Given this list of marker genes YAP1, PRKAA2, UMODL1, USP17L6P, USP17L24, NPC1, JAK2, ZFP36L1, HAND2, CARM1, CAPN10, EIF2S1, IL6, MIR182, SRSF6, PLA2G1B, SAV1, WNT11, TCF7L2, NKX2-6, CAST, CDKN1B, SFRP4, PDX1, TIA1, ADAR, HDAC3, PLA2R1, NEUROD1, TMF1, ESR1, MIR675, GSN, BOK, ISL1, BTC, WFS1, ITGB3BP, HMOX1, NUPR1, NKX2-5, BCL2, PKHD1, STK4, PPARA, PRKAA1, CFLAR, ZFP36, MIR4516, BAX, RB1 (NCBI Gene Id 92728), SERPINB13, PIAS4, MDK, ATOH1, here is a description of the gene set: studied in species Homo sapiens Human Gene Set: GOBP_REGULATION_OF_EPITHELIAL_CELL_APOPTOTIC_PROCESS Any process that modulates the frequency, rate or extent of epithelial cell apoptotic process.